Given this list of marker genes TCF25, SEC11A, RNF181, UTP4, JADE1, PAIP2, SPRED2, CD52, CDKAL1, BTBD19, SNX30, ZBTB4, SELENOM, YIPF5, PRPSAP2, PMS2, ASPSCR1, RNF41, BNIP2, POU2F1, FBLIM1, NCCRP1, PDP1, MLF2, AIRIM, SMO, PPFIA4, AAK1, ORC5 (NCBI Gene Id 5001), IPMK, MAF1, ARHGAP19, TMEM41B, LMBRD1, TNNC1, CRIPT, TMEM178A, CIAO1, APPL2, MEAK7, KIAA0319L, ZMYM1, MAPK4, SCOC, HCFC2, UBFD1, RHBDD3, TMEM40, DEF8, C1GALT1, FYB1, HGS, SYCN, CFAP410, KIF2A, BLZF1, AP4M1, TMEM151B, RNASEK, PBXIP1, DEPDC5, FAM204A, CAMK2G, ZFYVE19, TBC1D24, MKRN2, CCDC71L, PURG, ATG5, PTGR2, MYLIP, VTI1A, HP, FOXN2, ELOF1, LCMT2, MTF2, EDEM2, TRIM23, GIMAP7, PRKAB1, LSAMP, ATXN7L3, PIGB, PDRG1, RBM7, TXNL4B (thioredoxin like 4B), UBC, DAPK3 (death associated protein kinase 3), MIEF1, TMEM63A, GTDC1, RB1, TMEM165, CXXC1, CSRNP3, PSMA4, GDF15, PHKG2, VPS39, SERAC1, FLVCR1, PIGH, AKAP8 (NCBI Gene Id 10270), PSMD14, PRUNE1, NELFA, PIGX, CLPTM1L, NINJ2 (ninjurin 2), INHBA, GRINA (NCBI Gene Id 2907), RPS6KB1, SEC14L2, TMEM199, BRD9, PLEKHA8, LTN1, C4orf46, CRAMP1, HNRNPDL, ATG4B, TMEM222, SEPHS2, DBP, SH3BP2, DCAF10, PDE6D, CRYZL1, EPHB2, NDUFA9, ACP3, MAP7D1, TIMP4, IMPACT, RIMS3, GUCD1, CLK4, TRAPPC2, FOXE3, CCDC47, SMARCD2, TRAPPC2B, IFT57, SLC6A13, ZNF569, MAK (NCBI Gene Id 4117), SLC52A2, GPS2, CIRBP, BAHD1 (NCBI Gene Id 22893), SUMO3, BST1, ERAP1, SGPP2, NUP62, RNMT, IPPK, CLN8, COPZ1, KRTAP13-2, OGG1, C1orf74, C5orf34, HSDL2, UTP15, CPLX3, TMEM134, NRTN, HECTD3, MEX3D, PTDSS2, DDC, MOB3A, SLX4, NPLOC4, USPL1, EGFL8, CLMN, GNAS-AS1, SOS2, PLA2G7, MAP3K21, PEF1 (penta-EF-hand domain containing 1), BTBD1, MARCO, LIPT1, TAT, HDAC8, ZFC3H1, BMP7, CYP2U1, LIPT2, LTF, RCOR3, CD3G, HBP1, MOAP1, KATNBL1, TVP23B, here is a description of the gene set: The recent discovery of the human B1 cells, identified by the expression of CD20, CD27 and CD43 in absence of expression of CD70 and CD69 has been subject of debate. Some studies have raised the possibility that these cells are B cells differentiating towards the plasmablast and plasma cell stage rather than being the human counterpart of murine B1 cells. No further in depth studies have been performed. Therefore, a functional comparison was made between, the proposed B1 cells and plasmablasts. We observed that for several functional characteristics (distribution of isotypes of spontaneously producted antibodies, production of antigen-specific antibodies after vaccination with both T-cell dependent as well as T-cell independent antigen, the proposed B1 cells behaved similar to plasmablasts. In addition, we were able to differentiate the proposed B1 cells in vitro, indicating that they are not from a distinct lineage as the murine B1 cells. Gene expression analysis revealed that these cells cluster between memory B cells and plasmablasts, contradicting them being the genuine human counterpart of murine B1 cells, rather revealing a preplasmablast phenotype. Human Gene Set: GSE42724_MEMORY_VS_B1_BCELL_UP from publication Covens K, Verbinnen B, Geukens N, Meyts I, Schuit F, Van Lommel L, Jacquemin M, Bossuyt X (PMID 23613519) Genes up-regulated in B lymphocytes: memory versus B1. studied in species Homo sapiens